The following is a description of a gene set: studied in species Homo sapiens Human Gene Set: GOBP_NEGATIVE_REGULATION_OF_TRIGLYCERIDE_BIOSYNTHETIC_PROCESS Any process that decreases the rate, frequency, or extent of triglyceride biosynthesis. Triglyceride biosynthesis is the collection of chemical reactions and pathways resulting in the formation of triglyceride, any triester of glycerol., and this is the list of marker genes: FBXW7, SIK1, SIRT1, TMX1, MIR548P, MIR30C1